The following is a description of a gene set: from publication Chen Y, Wang X (PMID 31504780) Genes predicted to be targets of miRBase v22 microRNA hsa-miR-4329 in miRDB v6.0 with MirTarget v4 prediction scores > 80 (high confidence targets). studied in species Homo sapiens Human Gene Set: MIR4329, and this is the list of marker genes: KLF12, TEPSIN, MBP, STARD3NL, UBFD1, NEXMIF, LRP12, RNF166, DPY30, ZFP36L2, ARHGAP6, HLA-DPB1, XBP1, WNT16, COL14A1, SLC25A24 (solute carrier family 25 member 24), BCAT1, ZNF706, TSPAN9, C8G, TLL1, TRIM26, PPP2CA, NCCRP1, PSME4 (proteasome activator subunit 4), ACTN4, SDC2, TMEM47, EPSTI1, NAA15, TSSK1B, ARHGAP30, CACNA1G, ATG5, KHNYN, SLC6A16, YWHAE, RICTOR, SHOC1, CUL3, SPDYE5 (NCBI Gene Id 442590), POMT2, RASSF1, TLN2, RS1, LEMD3, DOCK2, ABL2 (NCBI Gene Id 27), XIAP, STK39, NUP153, ATF3, LRRC7, SMIM17, TENM3, ZC3HAV1, TOP2B, ING1, SLC44A1, BEST3, PDZRN4, FABP7, CSTF2, SEC14L1, RCBTB2, SPDYE6, UNC5C (unc-5 netrin receptor C), HSF2, PTGR3, SIAH3, RASEF, CTBP2, ZNF135, IER3IP1, DACT1, UCP2, CNST, ATAD2B, CADM1